Given this list of marker genes TBC1D4, CPLX2, GRIK5, SPHK1, RPH3AL, SYT7, SYT13 (synaptotagmin 13), CPLANE2, PRRT2, CPLX1, ANXA1, RPH3A, CORO1A (NCBI Gene Id 11151), ZNRF1, STXBP1, ANXA2, SYT5 (NCBI Gene Id 6861), SNCA, ERC2, SYT11, RAB3A, SYT2, SYT8 (NCBI Gene Id 90019), SYT9, ANKRD27, SYT3, CPLX4, DOC2B, ZNRF2, SLAMF1, SYT4, SYT1, DOC2A, CPLX3, C2CD5, here is a description of the gene set: Human Gene Set: GOBP_REGULATION_OF_VESICLE_FUSION Any process that modulates the frequency, rate or extent of vesicle fusion. species: Homo sapiens